The following is a description of a gene set: studied in species Homo sapiens Lateral clavicle hook An excessive upward convexity of the lateral clavicle. Human Gene Set: HP_LATERAL_CLAVICLE_HOOK, and this is the list of marker genes: CCN2, DYNC2I2, ORC1, RBM8A, DYNC2H1, IFT81, INPPL1, SLC35D1, INTU, SKI, IFT172, DYNC2I1, SCARF2, CDT1, NEK1, DYNLT2B